The following is a description of a gene set: Human Gene Set: GOBP_RETINAL_BLOOD_VESSEL_MORPHOGENESIS studied in species Homo sapiens The process whose specific outcome is the progression of a blood vessel of the retina over time, from its formation to the mature structure., and this is the list of marker genes: CYP1B1, NDP, FZD4, LAMA1, COL4A1, LRP5 (NCBI Gene Id 8058)